Given this list of marker genes UBB, TRAF6, RELA, NGF, SQSTM1, RPS27A, NFKB1, IKBKB (inhibitor of nuclear factor kappa B kinase subunit beta), IRAK1, NFKBIA, NGFR, UBA52, UBC, here is a description of the gene set: Human Gene Set: REACTOME_NF_KB_IS_ACTIVATED_AND_SIGNALS_SURVIVAL NF-kB is activated and signals survival species: Homo sapiens